Given this list of marker genes VHL, HTR1F, PCID2, TMC6, P2RX5, GUCA1A, EIF2B3 (eukaryotic translation initiation factor 2B subunit gamma), STOML2, VIPAS39, NOX5, JAM2, NFU1, SCN4A, PPIP5K1, DNAJC15, TRIM44, IL2RA, GALT, C17orf75, AMELY, WDR7, CPA4, GH2, ANXA2P2, ZNF286A (zinc finger protein 286A), MRPL40, TCTA, AKAP1, MRPL34, GPS2, ARHGEF3, PSMG2, PAN2, NAA38, ZNF74, AIMP2, R3HDM1, RAN, GFI1, NUP43, LRP5L, FNBP4, CBR3, HEXA, TRMT61B, SNRNP27, SHB, DIO1, BET1, GKN1 (gastrokine 1), DCTPP1 (NCBI Gene Id 79077), RIOX2, NAP1L2, ACAD8, PHC1, DARS2, PXMP2 (NCBI Gene Id 5827), RPL13, NUP133, TOM1L2, PIAS3, PRRC2B, PIGH, DCAF11, IL27RA, CD81, NHP2, PDE4A, SPATA20, OLFML3, CTNS, NUP155, F2R, HDAC1, PGR, RGS10, LYRM2, RNMT, RFX7, ZNF266, CCNJ, SINHCAF, NENF, PPP1R7, RASSF1, MAP3K4, STAT4, NAE1, DET1, IDH3B, TNPO3, AMPH, POLR3E, BCAT2, DNAJC16, CRYZ, NDUFB8, ATP13A1, PURA, ZNF395, POLR3C, TRAC, CDC37L1, BMPR1A, BBS9, LRRC47, CENPM, CD72, CDKL3, IARS1, PAICS, GOLGA3, PEPD, SSB, PRMT2, SMIM7, CSTPP1, POLDIP2, RETREG3, MRM2, CCNA2, DTWD1, EZR, OSBPL3, DKK2 (NCBI Gene Id 27123), RPS17P5, FBXO21, UBE2NL, SYNCRIP, TEDC2, PPOX, TGFBI, TXK, CYB5A, MLLT3, SUPV3L1, CDK2, CFHR4, BLMH, LINS1 (lines homolog 1), RARS1, MRPL17, RUVBL1, HIRIP3, MYBL1, FOXD1, S1PR1, SCP2, S100B, ELF3, FDFT1, APBA2, STARD7, UBE3C, TMED1, PSMD1, SYNGR3, CCNC, MTCH2, OMD, TCF12, POLR1F, DOK2, ARMCX5, EXT2, CDCA4, AKR1B1, RCN1, RRBP1, ZNF33B, PTMS, LPIN1, C1orf35, LONRF3, BAG2, ARL2BP, ENC1, EIF3F, RPN2, MBD3, LINC01565, SMIM10L1, AIMP1, RPL35A, CHD1L, ANO2, ABCF2, MRPL12, FDX1, COPS7B, ZPBP, ARMCX2, LSS, DNAAF5, RRM1, KIF2A, PRDM14, EEF2, DKK3, here is a description of the gene set: species: Homo sapiens Human Gene Set: GSE3982_NEUTROPHIL_VS_NKCELL_DN Genes down-regulated in comparison of neutrophils versus NK cells. from publication Jeffrey KL, Brummer T, Rolph MS, Liu SM, Callejas NA, Grumont RJ, Gillieron C, Mackay F, Grey S, Camps M, Rommel C, Gerondakis SD, Mackay CR (PMID 16474395) In the present study we used Affymetrix oligonucleotide microarrays to produce gene transcription profiles for the major leukocyte types in humans. This comprehensive dataset enabled us to not only establish which genes were expressed in each leukocyte type, but also which genes were expressed in each subset after activation. The used of a comprehensive dataset of gene profiles from all the major human leukocyte subsets enabled a novel and powerful means for identification of genes associated with single leukocyte subsets, or different immune paradigms.